The following is a description of a gene set: Genes predicted to be targets of miRBase v22 microRNA mmu_miR_708_5p in miRDB v6.0 with MirTarget v4 prediction scores > 80 (high confidence targets). from publication Chen Y, Wang X (PMID 31504780) Mouse Gene Set: MIR_708_5P species: Mus musculus, and this is the list of marker genes: Rnf186 (NCBI Gene Id 66825), Sbspon, Shprh, Dpysl4, Cbfa2t3, 6030498E09Rik, Dkk3, Rplp0, Zfp352, Lurap1l, Nav1 (neuron navigator 1), Vrk3, Tmigd3, Garre1, Ezh1, Ssrp1, Tns3 (tensin 3), Rps24, Mmp15, Slc44a5, Sde2, Aak1, Amph, Foxj3, En2, Uba1y, Zfp961, Tmem127, Tmem88 (NCBI Gene Id 67020), Ndrg2, Wbp4, Mta3, Rcvrn, Notch1, Chl1, Gpm6a, Drg2, Fam169a, Pitpna, Arih1